Given this list of marker genes Il7r, P4hb, Stip1, Il7, Tslp (thymic stromal lymphopoietin), Lsp1, Fosl2, Crkl, Hspd1, Gipc1, Hnrnph1, Jak1, Eno1, Hdgf, Btk, Pdia3, Atp5f1b, Rad23b, Hmgb1, Atic, Ybx1, Il2rg, here is a description of the gene set: studied in species Mus musculus Mouse Gene Set: GOBP_RESPONSE_TO_INTERLEUKIN_7 Any process that results in a change in state or activity of a cell or an organism (in terms of movement, secretion, enzyme production, gene expression, etc.) as a result of an interleukin-7 stimulus.